The following is a description of a gene set: studied in species Mus musculus Self-propelled movement of a cell or organism from one location to another in a behavioral context; the aspect of locomotory behavior having to do with movement. Mouse Gene Set: GOBP_LOCOMOTION_INVOLVED_IN_LOCOMOTORY_BEHAVIOR, and this is the list of marker genes: Dbn1, Rcan1, Mecp2, Ppp3cb, Fzd4, Slc25a46 (NCBI Gene Id 67453), Adgrl3, Gpr37, Ghsr, Arrdc3 (NCBI Gene Id 105171), Gla, Vps35, Cln6, Drd2, Gria1, Rcan2, Drd3, Myo5a